The following is a description of a gene set: Human Gene Set: GSE21927_EL4_VS_MCA203_TUMOR_MONOCYTES_DN Genes down-regulated in CD11b EL4 Tumor from C57BL6 mouse versus CD11b MCA203 Tumor from C57BL6 mouse. from publication Marigo I, Bosio E, Solito S, Mesa C, Fernandez A, Dolcetti L, Ugel S, Sonda N, Bicciato S, Falisi E, Calabrese F, Basso G, Zanovello P, Cozzi E, Mandruzzato S, Bronte V (PMID 20605485) Tumor growth is associated with a profound alteration of myelopoiesis, leading to recruitment of immunosuppressive cells known as myeloid-derived suppressor cells (MDSCs). Analyzing the cytokines affecting myelo-monocytic differentiation produced by various experimental tumors, we found that GM-CSF, G-CSF, and IL-6 allowed a rapid generation of MDSCs from precursors present in mouse and human bone marrow (BM). BM-MDSCs induced by GM-CSF+IL-6 possessed the highest tolerogenic activity, as revealed by the ability to impair the priming of IFN- -producing CD8+ T cells upon in vivo adoptive transfer. Moreover, adoptive transfer of syngeneic, GM-CSF+IL-6-conditioned MDSCs to diabetic mice transplanted with allogeneic pancreatic islets resulted in long term acceptance of the allograft and correction of the diabetic status. Cytokines inducing MDSCs acted on a common molecular pathway. Immunoregulatory activity of both tumor-induced and BM-derived MDSCs was entirely dependent on C/EBP transcription factor, a key component of the emergency myelopoiesis triggered by stress and inflammation. Adoptive transfer of tumor antigen-specific CD8+ T lymphocytes resulted in therapy of established tumors only in mice lacking C/EBP in myeloid compartment. These data unveil another link between inflammation and cancer and identify a novel molecular target to control tumor-induced immune suppression. We used gene expression analysis to identify those factors, secreted by tumor-infiltrating MDSC, which could drive emathopoiesis. Moreover we compare gene expression profile of tumor-induced MDSC, obtained from either the spleen and the tumor infiltrate of tumor bearing mice, and in vitro bone marrow-derived MDSC. studied in species Homo sapiens, and this is the list of marker genes: CGA, POPDC2, LASP1NB, HPF1, CBLN3, S100A7A, SEZ6L2, MAPKAPK5-AS1, CDC42BPG, GNPAT, SNN, RBP4, CNNM1, ZNF35, TAF12, NVL, BASP1, CENPF, FBXO40, FAM174A, KRT16, FBXO4, C3orf20, ZNF235, TIPRL, RNF8, SMAGP (small cell adhesion glycoprotein), ELP1, PSMG1, C11orf58, LINC01093, PHC3, GIMAP2, CKAP2L, DTNB, MFSD4B, RNFT1, ENPP5, GRAMD1C, GOSR1, PANX1, PITPNA-AS1, FAM228B, GPLD1, SRSF1, OMD, MT1F, N4BP2L1, PFKFB3, GLYATL2, GJA8, MIR622, AACSP1, APAF1, CA3, LINC00839, PLEKHM3, RPL26L1, ZMYM6, MARF1, GZF1, SPATS2, RARS2, ZNF573, ASPM, INTS13, SNORD123, USP48, RHOBTB1, FAM229B, BORCS8, RAD50, ADAP2, KLB, LINC01354, TNFRSF13B, MEIS3 (NCBI Gene Id 56917), PTPN22, LINC01816, FAM171A2, DUT, ZCCHC18, FGF13-AS1, ANGPTL3, PGM5-AS1, MSMB, TMOD2, PARP4, DCD, TUBGCP5, HIGD1A, METTL23, CSNK1G2-AS1, ZNF83, CYTH3, ZNF827, ASCL3, SPAST, SUPT7L, LHPP, LINC02433, CCDC28A, TUFT1, ABCD1 (ATP binding cassette subfamily D member 1), PICART1, FBXL22, RBBP7, GSTO2, ENTPD1, JADE3, ZNF607, CAPN3, PLPPR5-AS1, LEPROTL1, STAG3, SPTLC2, CLNK, RBM47, TACC2, ALDH1A2, MEGF6, LINC01191, CLDN4, PRXL2C, USP6NL, COMMD8, ROGDI, COX11, ZNF408 (zinc finger protein 408), JAKMIP2-AS1, FERRY3, CCAR1, SCAPER, GHRH, PDZK1IP1, GRM2, SMARCD3, WHAMM, NEFL, CELF6, GTPBP10, TEX101, CCDC62, METTL25B (methyltransferase like 25B), CASP8, MRC2, MBTPS2, GOLGA5, HKDC1, EVPL, MYO19, URB1-AS1, ACVR1C, RAPGEFL1, AQP2, ANXA2, CCNE2, TTC39B, C1orf50, RBM26-AS1, DCAKD, TGFB1I1, TRIM63, FKTN, CFHR2, PCDHGA4, SC5D, CEP120, GRIA3, ACTN3, KLHL5, TMEM61, MELTF-AS1, NGEF, IPO8, PKD1P1, CRTAC1, MPHOSPH6, MED25, ACADSB, FOXL2, SHPRH, BDNF-AS, CAST, KCNAB1 (NCBI Gene Id 7881), ARID4A (NCBI Gene Id 5926), MICALL2, GABARAPL3, IRAK2, GAPDHP62, WNT9A, PSMD12, FOXN3